Given this list of marker genes ZNF281, MDGA2, SETD7, ABCA1, ATP1B1, KCNS3 (NCBI Gene Id 3790), PARP6, MAP3K3, TMEM86A, SMG1 (SMG1 nonsense mediated mRNA decay associated PI3K related kinase), PTGFRN, MMP16, SLC12A5, HMGA2, MEIS2, EPHA8, SREK1, PRICKLE2, RAP2A, HIPK2, PDGFRA, MRPS25, USP32, ICA1, CLPX, SGCD, CNNM1, KCNMA1, ESCO1, BTBD2, CDK6, GPR88, NR4A2, BCL11A, FBXW7, ANKRD29, HIPK1, RLIM, KPNA3, CREBZF, B3GALT2 (NCBI Gene Id 90195), EN2, MORF4L1, CNTN4, PAPPA, KPNA4, MORF4L2, CDK14, SOX11, ZCCHC14, NFIX, USP32P2, DONSON, NAA30, SNRK, EEF1A1, CAMK2G, OLFM1, NPY, CHN2, GRIA3, ST18, FBXO33, ACACA, LGI1, USP6, CDR2L, MLLT3, CACNA1C, CSNK1D, ARID5B, SATB2, IRS2, PURB, CASC3, SLITRK3, PPARGC1A, OGT, MECOM, SALL3, SCN8A, CALML4, SEC24C, YWHAH, DPYSL5, NUFIP2, SLC25A25, MAP3K7, MAP4K4, SHANK2, NAA15, PRKAA1, HADHB, here is a description of the gene set: Genes having at least one occurence of the motif CAATGCA in their 3' untranslated region. The motif represents putative target (that is, seed match) of human mature miRNA hsa-miR-33 (v7.1 miRBase). studied in species Homo sapiens Human Gene Set: CAATGCA_MIR33